The following is a description of a gene set: Mouse Gene Set: GOBP_SPINDLE_CHECKPOINT_SIGNALING A signaling process that that controls a cell cycle checkpoint that originates from the mitotic or meiotic spindle. species: Mus musculus, and this is the list of marker genes: Diaph3, Aurka, Incenp, Apc, Gen1, Knl1, Spc25, Xrcc3, Ccnb1-ps, Dusp1, Lcmt1, Prap1, Ttk, Plk1, Bub3, Arhgap33os, Birc5, Stil, Usp44, Bub1b, Spc24, Ska3, Anapc15, Cdca8, Kntc1, Atm, Pcid2 (PCI domain containing 2), Trip13, Cep192, Zwilch, Bub1, Haspin, Cdc20, Zw10, Prpf4b, Psmg2, Chfr, Mad2l1bp, Tex14, Nuf2 (NUF2, NDC80 kinetochore complex component), Aurkb, Zwint, Zfp207, Khdc3, Cdk5rap2, Ccnb1, Cenpe, Hsf1, Mad2l1, Ndc80, Ska1, Mtbp, Dync1li1, Ik, Spdl1, Klhl22, Tpr, Anapc15-ps, Mad1l1